Given this list of marker genes Ins1, Rfk, Ins2, Slamf8, Park7, Drd5, here is a description of the gene set: Any process that modulates the activity of the enzyme NAD(P)H oxidase. Mouse Gene Set: GOBP_REGULATION_OF_NAD_P_H_OXIDASE_ACTIVITY studied in species Mus musculus